Given this list of marker genes TMSB4X, NKX1-1, HSPE1, C9orf85, TMEM191A, EEF1A1P9, here is a description of the gene set: Genes down-regulated in CD4-positive, alpha-beta memory T cell 7d vs 0d in adults (18-45) after exposure to BCG vaccine, time point 7D, administered PO (oral). Comment: top 100 most significantly altered genes comparing Day 0 and Day 7 responses directly ex vivo from publication Hoft DF, Xia M, Zhang GL, Blazevic A, Tennant J, Kaplan C, Matuschak G, Dube TJ, Hill H, Schlesinger LS, Andersen PL, Brusic V (PMID 28853442) species: Homo sapiens Protective efficacy of Bacillus Calmette-Guerin (BCG) may be affected by the methods and routes of vaccine administration. We have studied the safety and immunogenicity of oral (PO) and/or intradermal (ID) administration of BCG in healthy human subjects. No major safety concerns were detected in the 68 healthy adults vaccinated with PO and/or ID BCG. Although both PO and ID BCG could induce systemic Th1 responses capable of IFN-gamma production, ID BCG more strongly induced systemic Th1 responses. In contrast, stronger mucosal responses (TB-specific secretory IgA and bronchoalveolar lavage T cells) were induced by PO BCG vaccination. To generate preliminary data comparing the early gene signatures induced by mucosal and systemic BCG vaccination, CD4<sup>+</sup> memory T cells were isolated from subsets of BCG vaccinated subjects pre- (Day 0) and post-vaccination (Days 7 and 56), rested or stimulated with BCG infected dendritic cells, and then studied by Illumina BeadArray transcriptomal analysis. Notably, distinct gene expression profiles were identified both on Day 7 and Day 56 comparing the PO and ID BCG vaccinated groups by GSEA analysis. Future correlation analyses between specific gene expression patterns and distinct mucosal and systemic immune responses induced will be highly informative for TB vaccine development. Human Gene Set: HOFT_CD4_POSITIVE_ALPHA_BETA_MEMORY_T_CELL_BCG_VACCINE_AGE_18_45YO_7DY_DN